The following is a description of a gene set: species: Homo sapiens Human Gene Set: WP_PROSTAGLANDIN_SIGNALING Prostaglandin signaling, and this is the list of marker genes: PTGES, IL6, AHR, IFNA1, TNF, IRF7, NLRP3, IL1B, CXCL9, VEGFA (vascular endothelial growth factor A), CCL2, CCR2, CXCL1, IL17F, IL1A, CD28 (CD28 molecule), CXCL8, PTGER2 (NCBI Gene Id 63381), PYCARD, CCL3 (NCBI Gene Id 6348), CSF1, NFKB1, IL12A, KLRD1, PIK3CG, CASP1, IL17A, CXCL10, PTGER4, MMP9 (NCBI Gene Id 4318), TGFB1, IFNG, AREG